The following is a description of a gene set: species: Homo sapiens Reactome Pathway: Unwinding of DNA part of: DNA strand elongation DNA Replication is regulated accurately and precisely by various protein complexes. Many members of the MCM protein family are assembled into the pre-Replication Complexes (pre-RC) at the end of M phase of the cell cycle. DNA helicase activity of some of the MCM family proteins are important for the unwinding of DNA and initiation of replication processes. This section contains four events which have been proved in different eukaryotic experimental systems to involve various proteins for this essential step during DNA Replication., and this is the list of marker genes: MCM5, MCM4, CDC45, MCM3, GINS4, GINS1, GINS2, GINS3, MCM7, MCM6, MCM8, MCM2